Given this list of marker genes Bmal1, Dlg4, Srp9, Grin2a, Ipo13, Zpr1, Calr, Larp7, Tinf2, Lyset, Zbtb7a, Rab6b, Gak, Hsp90aa1, Pex1, Zfyve16, Trmt10b, Emc9, Taf8, Hikeshi, Sumo1, C2cd3, Cd68, Atr (ataxia telangiectasia and Rad3 related), Morc3, Arl2bp, Cwh43, Mtor, Nop53, Kdelr1, Pphln1, Emc8, Agt (angiotensinogen), Kdelr3, Nabp2, Nuak2, Arl13a, Pacs1, Agrn, Rab34, Ywhae, Insig1, Traf3ip2, Asb3 (ankyrin repeat and SOCS box-containing 3), Prkaa1, Rab23, Wrap53, Hspa1l, Ccdc47, Pin1rt1, Pot1b, Ift56, Jarid2, Tmco6, Htatsf1, Fis1, Hm629797, Gga3, Prkcz, Parp9, Mir208b, Chp2, Spdya, Knl1, Bbs4, Pex16, Pcare, Sting1, Gnl3l (NCBI Gene Id 237107), Rom1, Ubxn2b (NCBI Gene Id 76194), Cript, Ddx5, Gja1, Ppp3r1, Cry2, Lmnb1 (NCBI Gene Id 16906), Cct7, Tnfrsf1a, Sec13, Lamp1, Sirt1, Emc4, Gabarap, Gpc4, Vps37a, Cep63, Lef1, Polr1a, Oxa1l, Fam83d, Pmpca, Dnaaf11, Tnks, Mgat3, Msh2, Hspd1, Utp25, Gga1, Gpc6, Pink1, Tcp1, Grpel1 (GrpE-like 1, mitochondrial), Akap11, Tpp1, Prkaca, Herpud1, Nup54, Get4, Apod, Fgf9, Dync2h1, Akt1, Zfand2b, Nptx1, Ik, Rrs1, Nvl, Zmynd8, Nup153, Carm1, Cct4, Dtx3l, Bax, Sec61a1, Bag3, Os9, Srprb (signal recognition particle receptor, B subunit), Nudcd3, Txnip, H1f5, Tmed2, Grb2, Rab3gap2, Fbxo4, Ei24, Xpa, Nup214, Rassf5, Cav2, Hacl1, Tctn2, Pard6a, Filip1, Cct5, Nup155, Nutf2, Bag1, Bnip3l, Ctcf, Spcs2, Csnk1d, Pes1, Lrrk2, Olfm2, Tmem98, Ppp1r9b, Tulp1, D1Pas1, Cct8 (NCBI Gene Id 12469), Hgs (NCBI Gene Id 21921), Iffo1, Nup88, Ybx1, Neurl3, Rab8b, Mmgt1, Ccdc14, Bag4, Glis2, Pex14, Dok7 (docking protein 7), Dclk3, Vegfa, Mdc1, Flna, Lamtor4, Msn, Pom121l2, Mrnip, H2ax, Grpel2, Arl6, Atrx, Bcap29, Lamp2, Bard1, Pygo1, Atg14, Moap1, Tmem107, Rabep1, Rpa1, Snx16, Abra, Cc2d2a, Il10ra, Rapsn, Epm2a, Ttc21a, Camk2a, Tmem108, Eif2ak1, Lats1, Tbrg1, Mtch1, Ap4m1, Gper1, Klhl21, Wbp2, Bbs2, Chmp7 (charged multivesicular body protein 7), Tomm7, Nsfl1c, Mtch2, Kpna7, Wwtr1, Tollip, Mgarp, Cacna2d2, Bicd2, Potefam3a, Pias4, Macf1 (microtubule-actin crosslinking factor 1), Snhg15, Srsf1, Mamdc4, Shh, Sec62, Ctnna1, Ttc21b, Tcirg1, Akirin2, Vps13d, Tspan10, Kpnb1, Pex19, Park7, Syk, Aurka, Xpo1, Ranbp2, Nf1, Ndp, Sun1, Wapl, Nutf2-ps2 (nuclear transport factor 2, pseudogene 2), Pkia, Rcsd1, Dnajc15, Irgm2 (NCBI Gene Id 54396), Ift122, Eps15, Ect2, Vcp, Mapre3, Ssb, Rab11a, Appl2, Rnf186, Tcf7l2, Rab29, Nolc1, Cacnb4, Mon1a, Ifng, Tek, Pam16, Pin1, Zfp827, Ccdc66, Cabp1, Tpr, Dclk2, Scg3, Hdgf (heparin binding growth factor), Spry2, Trappc12, Golph3, Marchf5, Mdfic, Cep78, Lmnb2, Ankrd13c, M6pr, Tfrc, Ehd1, Cct3, Asb15, Pot1a, Msx1, Rcc2 (regulator of chromosome condensation 2), Vps54, Mon1b, Mmp12, Atp5if1, Gnptab, Cdk1, Spin1, Tnpo2 (transportin 2 (importin 3, karyopherin beta 2b)), Tmed10, Ryr2, Tomm40l, Get1, Lmna (lamin A), Cplane1, Tyk2, Nup62, Nr4a1, Jup, Ppp1r15a, Pik3c3, Iqsec2, Folr1, Entr1, Zdhhc15, Taf3, Timm9, Pex26, Rasl2-9, Adam10, Ywhab, Trim8, Cd81, Bmpr1a, Bbs1, Vcpip1, Dctn2, Ripor1, Trim29, Cep72, Snx10, Bmpr2, Cep83, Emc1, Six4, Ipo4, Kpna1, Gdap1, Traf6, Brd3, Xrcc5, Dnm1l, E2f3, Ahi1, Iqce (IQ motif containing E), Wrn, Arl1, Trp53, Timm8a1, Jak2, Otud7b, Supt7l, Dlg2, Ndufa13, Fam53c, Rad17, Fbxw7, Cdk9, Psen1, Arl5b, Med1, Srp54a, H2ac4, Srp72, Lonp2, Rap1a, Adam22, Champ1, Tulp2, Ccdc39, Macroh2a2, Pex3, Ncln, Trim28, Mtbp, Srgn, Lgi1, Nfkbia, Frey1, Hook3, Arf6, Abhd17b, Sgtb, Aup1, Pex2 (peroxisomal biogenesis factor 2), Nrp1, Mcm9, Vps13c, Nup50l, Rer1, Kalrn, Pdcd5-ps, Pinx1, Glul, Spag5, Kics2, Abhd17c, Pex7, Csrp3, Sin3a, Ift140, Pml, Bcs1l, Nup50, Nup107, Tor1b, Naca, Slf2, Ins2, Timm50, Gas8, Parp3, Tasor, Dag1, Ranbp6, Ctcfl, Timm17a, F2, Ing1, Nf2, Arl13b, Magi2, Rpf2, Angpt1, Rrp7a, Nedd4, Kif20b, Timm17b, Nup188, Wnk1, Sec61b, Pex5, Srebf1, Timm13, Apc, Maip1, Stat3, Dcp1a, Mid2, Bmp2, Ipo11, Lhcgr, Aurkb, Ddx3x, Ubr5, Emc7, Lamtor5, Vps25, Vps41, 1700009N14Rik, Dusp18, Eif4enif1, Tgfb1, 4930550C14Rik, Potefam3b, Htr2a, Ipo8 (NCBI Gene Id 50504), Timm23, Clu, Pmpcb, Ipo5, Pik3r4, Rab3ip, Nup58, Ghsr, Siah3, Card10, Parl (presenilin associated, rhomboid-like), Vps53, Vps28, Eif2ak3, Agap3, Cldn18, Mavs, Tert, Mark4, Prkaa2, Rab33b, Stk3, Wdr35, Trim40, Crebbp, Lrwd1, Lep, Ipo9 (importin 9), Tbc1d32, Sumo3, Ufm1, Agtr2, Akap1, Zdhhc1, Tram1, Zwilch, Tnpo1, Tspan17, Xbp1, Elavl1, Mapre2, Tmem201, Ptgs2, Abca7, Fam149b, Spcs3, Pex13, Sorl1, Ttk, Hsp90ab1, Stk4 (NCBI Gene Id 99242), Ctdnep1, Lilrb4b, Ciz1, Tspo, Cttnbp2nl, Mms22l, Mapk14 (NCBI Gene Id 26416), Tmem30a, Sp100, Kntc1, Phip, Mis18a, Rab10, Lemd2, Il33, Stil (NCBI Gene Id 230631), Chga, Gcc2, Meak7 (NCBI Gene Id 74347), Pibf1, Optn, Pkig, Syne1, Arfrp1, Hspa8, Ipo7, Sec16a, Uaca, Stk11, Kpna2rt, Ankrd6, Cntln, Mark3, Ankrd13a, Paqr3, Sppl2c, Abl1, Rapgef4, Luzp1, Nipbl, Kpna2, Dmap1, Emc3, Appl1, Dyrk1a, Cep68, Ptpn23, Prkd1, Tnpo3, Pex5l, Lzts2, Aplf, Gfy, Zic1, Sprn, Irgm1, Sh3glb1, Map2k1 (NCBI Gene Id 26395), Ilrun, Kpna4, Topors, Pik3r1, Nup62cl, Tmco1, 4933427D14Rik, Tgfb2 (NCBI Gene Id 98738), Kcnq2, Tnfaip3, Lamtor1, Acd, Adrb1, Egfr (NCBI Gene Id 13649), Grxcr2, Plk1, Tardbp, Cep131, Plrg1, Mepce, Odad4, Cep192, Grk2, Rap1gds1, C1ql2, Dclk1, Immp1l, Dhx9, Vps8, Cacng2, Gpr137b (G protein-coupled receptor 137B), Emc6, Arf4, Srp54b, Six2, Txn1, Erbb2, Fermt2, Tmem126a, Ankrd10, Bub1b, Ubl4a, Hcls1, Get3, Cfap53, Cdkn1a, Filip1l, Nol8, Kif2c, Spg11, Vps36, Cngb1, Pttg1ip2, Rraga, Bmp4, Trim69, Aifm1, Timm21, Vps4a, Cog3, Map1a, Dusp21, Vrk1, Adcy10, Bbc3, Zw10, Cfap58, Timm22, Nol3, Tomm40, Xrcc4, Maged1, Stag3, Nbea, Airn, Ankrd66, Fam53b, Fbxo7, Dkc1, Vps35, Rragc, Ruvbl2, Arl5a, Gphn, Emc10, Tulp3, Sec16b, Pom121, Neto2, Pgr, Atp6v1d, Ddit3, Hras, Hnf4a, Hhex, Cep250, Agk, Zfand2a, Fam76b, Sec61a2, Dnaja1, Cdkl5, Inpp5e, Scarb2, Nutf2-ps1, Cnep1r1, Hk1, Gnl3, Esr1 (estrogen receptor 1 (alpha)), Brca1 (breast cancer 1, early onset), Cdh1, Gas2l2, Hspa4, Sun2, Timm29, Cdk5, Srp68, Rpl11, Ddrgk1, Dvl1, Irs1, Zdhhc5, Ints13 (integrator complex subunit 13), Erbb4, Pola2, Rbm22, Bid, Cct6a, C1ql3, Srpra, Tax1bp1, Efcab7, Rad21, Tctn1, Sys1 (NCBI Gene Id 98891), Nup93, Ropn1, Cacng7, Mterf4, Mdm2 (NCBI Gene Id 69330), Pmaip1, Mapk1, Asap1, Nomo1, Kpna6, Spo11, Paf1, Syt11, Il6, Pex10, Tomm20l, Cbl, AU015836, Mipep, Cdk20, Micall1, Tomm20, Nptx2, Rpa2, Kptn, Kpna3, Cox18, Trim37, Kcnq3, Gdi2, Srp14, Ptpn5, Folr2, Abhd17a, Rab6a, Spidr, Musk, Pacsin2, Emc2, Ogt, Tomm70a, Rock2, Nup133, Ep300, Mapk15, Vps13a, Umod, Edn1, Tia1, Cc2d2b, Rpain, Pikfyve, Immp2l, Lrp2 (NCBI Gene Id 99378), Nphp4, Bbip1, Arl5c, Igtp, Glp1r, Ezh2, Cd36, Ppp2r2b (NCBI Gene Id 72930), Rdx, Prkn, Nmd3, Tesk1, Heatr3, Skp1, Tsc2, Nr5a1, Lamp3, Arxes1, Zfand6, Disc1 (disrupted in schizophrenia 1), Cdk5rap3, Cpe, Ank2, Mia3, Parp1, Jak1, Gbp4, Zbtb16, Smurf1, Akap5, Nup35, Pcm1, Intu, Sqstm1, Ssr3, Tmem147, Szt2, Obsl1 (obscurin-like 1), Fkbp8, Daxx, Arl8b, Prkcd, Samm50, Terf2, Rab35 (RAB35, member RAS oncogene family), Grik5, Rhno1, Gpsm2, Scml2, Dzip1l, Atg9a (autophagy related 9A), Six1, Bicd1, Srp19, Cog7, Terf1, Zc3h12a, Bub3, Osbpl8, Ppp3ca, Sirt4, Crocc, Arl3, Gbp5, Rab11fip3, Glmp, Pak1, Setd2, Man1a, Git1, Hspa5, Chchd4, Tub, Dnlz, Lhfpl4, Tnks2, Limk2, Ngfr (nerve growth factor receptor (TNFR superfamily, member 16)), Hnrnpm, Dcp1b, Phb2, Timm44, Cenpa, Macroh2a1, Dnajc19, Zdhhc3, Gckr, Cubn, Wdr83os, Dnajb6, Bcap31, Fkrp, Hdac3, Cse1l, Gsk3b (NCBI Gene Id 98033), Tram1l1, Npm1, Mid1, Rangap1, Sh3kbp1, Neurl1b, Lmbrd1, Nrxn3, Hnrnpu, Smc5 (structural maintenance of chromosomes 5), Ncoa4, Gsk3a, Cenpq, Rab7 (NCBI Gene Id 19349), Pik3r2, Vwc2, Zmynd10, Bbs9, Ap3b1, App, Arxes2, Adar, Haspin, Lrsam1, Sh3bp4, Sirt6, Washc2 (NCBI Gene Id 68154), Cdkn2a, Lats2, Tomm34, Snupn, Lamp5, Rab3gap1 (NCBI Gene Id 69346), Usp9x, Esco2, Tnik, Insig2, Htt, Pax6, Fam53a, Romo1, Tomm22, Stam, Lilrb4a, Bag6, Fermt1, Sufu, Trp53bp1, Ywhaz (tyrosine 3-monooxygenase/tryptophan 5-monooxygenase activation protein, zeta polypeptide), Atp13a2, Fam83h, Snf8, Ddx1, Sesn2, Gas2l1, Edem1, Cfl1, Ormdl3, Nup98 (NCBI Gene Id 330609), Spcs1, Slf1, Rnf4, Spdl1, Dlg1, Nup85, Sec61g, Ccdc88a, Aip, Tor1aip2, Rtn4, Chp1, Mcrs1, Sort1, Sec63, Mapt, Vps37b, Nos3, Diaph1, Ccdc40, Timm10, Mapre1, Spi1, Ppp3cb, Ift80, Sox9, Vps37d, Pdcd5, Ttbk2, Srp54c (signal recognition particle 54C), Cnih3, Notch1, Mfhas1, Rab8a, Chmp4b, Prkcq, Smo, Cacng3, Laptm5, Gfer, Cct2, Drd1, Nrarp, Prickle1, Col1a1, Tor1aip1, Ran, Arl2, Cep350 (NCBI Gene Id 74081), Invs, Six3, Topbp1, Spata7, Ezr, Tomm5, Ift20, Kdelr2, Ap3d1, Atf2, Ahr, Vps26b, Gli3, Gabarapl2, Fsip2, Rala, Mfsd1, Rab5if, Tonsl, Larp7-ps, Sgta, Mfn2, Neto1 (NCBI Gene Id 246317), Tram2, Nbn, Isg15, Btf3, Ubac2, Mcm8, Becn1 (beclin 1, autophagy related), Brca2, Hk2, Cyren (cell cycle regulator of NHEJ), Mff, Vps37c, Tsg101, Golph3l, Sarm1, Mia2, Nptxr, Nfatc3, Vapa, Src, Brd2, Gbf1, Cd2ap, Tex15, Hyal2, Dzip1, Pttg1ip, Numa1, Ins1, Pex6, Rb1 (RB transcriptional corepressor 1), Zfp423, Tmed10-ps, Pex12, Mcph1, Caml, Yap1, Terf2ip, Ptpn22, Wdr19, Bcl3, Fyn, Egf, Brme1, Lztfl1, Tor1a, here is a description of the gene set: A process in which a protein is transported to, or maintained in, a location within an organelle. Mouse Gene Set: GOBP_PROTEIN_LOCALIZATION_TO_ORGANELLE studied in species Mus musculus